The following is a description of a gene set: Interleukin-23 signaling Mouse Gene Set: REACTOME_INTERLEUKIN_23_SIGNALING studied in species Mus musculus, and this is the list of marker genes: Il23r, Stat3, Il12b, P4hb, Tyk2, Il23a, Jak2, Il12rb1